The following is a description of a gene set: Human Gene Set: GOBP_DNA_DEAMINATION species: Homo sapiens The removal of an amino group from a nucleotide base in DNA. An example is the deamination of cytosine to produce uracil., and this is the list of marker genes: APOBEC3F, EXOSC6, APOBEC3G, APOBEC3D, APOBEC3C, APOBEC3H, AICDA, CDADC1, APOBEC3A, EXOSC4, EXOSC5, EXOSC3, APOBEC3B